Given this list of marker genes OGN, HS6ST2, SELE, GREB1, PLN, here is a description of the gene set: from publication Lu C, Bonome T, Li Y, Kamat AA, Han LY, Schmandt R, Coleman RL, Gershenson DM, Jaffe RB, Birrer MJ, Sood AK (PMID 17308118) studied in species Homo sapiens Human Gene Set: LU_TUMOR_ENDOTHELIAL_MARKERS_DN Therapeutic strategies based on antiangiogenic approaches are beginning to show great promise in clinical studies. However, full realization of these approaches requires identification of key differences in gene expression between endothelial cells from tumors versus their normal counterparts. Here, we examined gene expression differences in purified endothelial cells from 10 invasive epithelial ovarian cancers and 5 normal ovaries using Affymetrix U133 Plus 2.0 microarrays. More than 400 differentially expressed genes were identified in tumor-associated endothelial cells. We selected and validated genes that were overexpressed by 3.6- to 168-fold using real-time reverse transcription-PCR and/or immunohistochemistry. Among these, the polycomb group protein enhancer of Zeste homologue 2 (EZH2), the Notch ligand Jagged1, and PTK2 were elevated 3- to 4.3-fold in tumor-associated endothelial cells. Silencing these genes individually with small interfering RNA blocked endothelial cell migration and tube formation in vitro. The present study shows that tumor and normal endothelium differ at the molecular level, which may have significant implications for the development of antiangiogenic therapies. Genes specifically down-regulated in tumor endothelium.